The following is a description of a gene set: Human Gene Set: PID_SYNDECAN_3_PATHWAY Syndecan-3-mediated signaling events from publication Schaefer CF, Anthony K, Krupa S, Buchoff J, Day M, Hannay T, Buetow KH (PMID 18832364) studied in species Homo sapiens, and this is the list of marker genes: CTTN, PSEN1, NCSTN, CXCL8, MC4R, EGFR, PSENEN, PTN, FYN, SDC3, AGRP, APH1A, APH1B, CASK, POMC, NCAN, SRC